Given this list of marker genes Ung, Neil2 (nei like 2 (E. coli)), Neil1 (NCBI Gene Id 72774), Tdg, Smug1, Nthl1, Ogg1, Mbd4, here is a description of the gene set: Cleavage of the damaged pyrimidine Mouse Gene Set: REACTOME_CLEAVAGE_OF_THE_DAMAGED_PYRIMIDINE species: Mus musculus